The following is a description of a gene set: Human Gene Set: GOBP_POSITIVE_REGULATION_OF_ORGANELLE_ASSEMBLY Any process that activates or increases the frequency, rate or extent of organelle assembly. studied in species Homo sapiens, and this is the list of marker genes: CNOT6, SEPTIN7, WDR45, TRIM32, MNS1, SNX4, SNX30, MOAP1, SASS6, IFT20, BECN1, RALB, DYNC1H1, CEP120, CCDC88A, CENPJ (centromere protein J), CEP135, ATG2A, MAPK15, MARK4, SRC, ATG5, ENTR1, POC1B, TAPT1, MSN, RP1, TTBK2, PIP4K2B, STX18, GPSM2, IL5, ARHGAP35, PAN2, ATMIN, SPAG5, ULK1, RAB11FIP3, CNOT2, SNX7, CAPRIN1, SAXO1, FUZ, HSF1, ZMYND10, PLK4, RHOA, KCTD17, UBAP2L, SNX18, SDC1, IFT88, PIP4K2A, CROCC, CNOT6L, ELAPOR1, NUP62, SH3GLB1, HTT, HAP1, LCP1, SEPTIN9, CCDC15, RAB3GAP1, PIP4K2C, ARHGEF5, GSK3B (glycogen synthase kinase 3 beta), VPS4B, WIPI1, CEP295, STIL, MAPK9, LRSAM1, PPP1R35, NUMA1, BBS4, SDC4, WRAP73, PAN3, RAB3GAP2, SDCBP, TNF, PDCD6IP, CAPG, CCP110, FSCN1, DZIP1, CNOT1, CSF2